The following is a description of a gene set: Human Gene Set: HP_BROAD_METACARPALS studied in species Homo sapiens Broad metacarpals Abnormally broad metacarpal bones., and this is the list of marker genes: IFT140, MMP2, IHH, FBN1, TFE3, MMP14, BMPR1B, GNAS, SLC26A2, EXTL3, BGN, GDF5, PDE4D, ADAMTS10, FGFR1, GLB1, DDR2, NPR2, DNMT3A